The following is a description of a gene set: Human platelets are anucleate blood cells that retain cytoplasmic mRNA and maintain functionally intact protein translational capabilities. We have adapted complementary techniques of microarray and serial analysis of gene expression (SAGE) for genetic profiling of highly purified human blood platelets. Microarray analysis using the Affymetrix HG-U95Av2 approximately 12 600-probe set maximally identified the expression of 2147 (range, 13%-17%) platelet-expressed transcripts, with approximately 22% collectively involved in metabolism and receptor/signaling, and an overrepresentation of genes with unassigned function (32%). In contrast, a modified SAGE protocol using the Type IIS restriction enzyme MmeI (generating 21-base pair or 22-bp tags) demonstrated that 89% of tags represented mitochondrial (mt) transcripts (enriched in 16S and 12S ribosomal RNAs), presumably related to persistent mt-transcription in the absence of nuclear-derived transcripts. The frequency of non-mt SAGE tags paralleled average difference values (relative expression) for the most abundant transcripts as determined by microarray analysis, establishing the concordance of both techniques for platelet profiling. Quantitative reverse transcription-polymerase chain reaction (PCR) confirmed the highest frequency of mt-derived transcripts, along with the mRNAs for neurogranin (NGN, a protein kinase C substrate) and the complement lysis inhibitor clusterin among the top 5 most abundant transcripts. For confirmatory characterization, immunoblots and flow cytometric analyses were performed, establishing abundant cell-surface expression of clusterin and intracellular expression of NGN. These observations demonstrate a strong correlation between high transcript abundance and protein expression, and they establish the validity of transcript analysis as a tool for identifying novel platelet proteins that may regulate normal and pathologic platelet (and/or megakaryocyte) functions. Human Gene Set: GNATENKO_PLATELET_SIGNATURE Top 50 most up-regulated genes in human platelet cells. from publication Gnatenko DV, Dunn JJ, McCorkle SR, Weissmann D, Perrotta PL, Bahou WF (PMID 12433680) species: Homo sapiens, and this is the list of marker genes: NRGN, OAZ1, MLH3, GPX1, DYNLL1, ACTB, PTMA, CFL1, H2AC20, B2M, HLA-C, H2AC6, ITGA2B, CD99, HLA-E, PKM, RGS10, ITM2B, RPL41, NCOA4, TLN1, FLNA, UBC, PF4, GNAS, TAGLN2, CLU, F13A1, H2AC18, MYL12A, SPARC, FTH1P5, MYL6, TUBA4A, YWHAH, H3-3A, RNF24, PPBP, TMSB4X, CCL5, FTH1, PGRMC1, HBB, H2BC14